Given this list of marker genes Neurod1, Psmd9, Mapk8, Tcf7l2, Ager, Spop, Atg7, Pdx1, Ngf, Eif2s1, Wfs1, Ryr2, Srsf6, Isl1, Cast, Hdac3, Capn10, here is a description of the gene set: Mouse Gene Set: GOBP_TYPE_B_PANCREATIC_CELL_APOPTOTIC_PROCESS Any apoptotic process in a type B pancreatic cell, a cell located towards center of the islets of Langerhans that secretes insulin. studied in species Mus musculus